The following is a description of a gene set: studied in species Mus musculus from publication Motenko H, Neuhauser SB, O'Keefe M, Richardson JE (PMID 26092688) Mouse Gene Set: MP_INCREASED_HISTIOCYTIC_SARCOMA_INCIDENCE Mouse genes annotated to increased histiocytic sarcoma incidence (MP:0009321) retrieved from the Mouse Genome Informatics database via MouseMine, and this is the list of marker genes: Stag1, Suz12, Stk4, Fasl, Ing2, Slc29a3, Abraxas1, Trp63, Pinx1, Trp53, Becn1, Dclre1a, Cop1, Fbxo4, Pole, Cdkn2a (cyclin dependent kinase inhibitor 2A), E2f1, Prdx1, Flt3, Nsmce2, Cdkn1a (cyclin dependent kinase inhibitor 1A), Crebbp, Rcbtb2